The following is a description of a gene set: The process in which a relatively unspecialized cell acquires specialized features of a trophoblast giant cell of the placenta. Trophoblast giant cells are the cell of the placenta that line the maternal decidua. species: Homo sapiens Human Gene Set: GOBP_TROPHOBLAST_GIANT_CELL_DIFFERENTIATION, and this is the list of marker genes: ELF5, MDFI, PLG, PLK4, HAND1, E2F7, E2F8, SOX15, SNAI1, NR2F2, SENP2, LIF, PRDM1, GJB5 (NCBI Gene Id 2709)